The following is a description of a gene set: Mouse Gene Set: GOMF_MRNA_3_UTR_BINDING Binding to a 3' untranslated region of an mRNA molecule. studied in species Mus musculus, and this is the list of marker genes: Utp23, Elavl1 (NCBI Gene Id 97501), Rbm24, Pum1, Khsrp, Larp1, Slirp (SRA stem-loop interacting RNA binding protein), Tia1, Gemin5, Hnrnpa1, Mir135a-1, Elavl3, Exosc7, Dazap1 (DAZ associated protein 1), Syncrip, Cpeb3, Mir9-1, Ddx5, Rc3h1, Mir874, Celf2, Mir24-2, Ago2 (NCBI Gene Id 70188), Mirlet7g, Pum2, Hnrnpd, Taf15, Igf2bp1, Rbm47, Mir24-1, Hnrnpa3, Tardbp, Ybx3, Cpeb4, Secisbp2l, Zfp36l2, Cirbp, Cpsf1, Csdc2, Zfp36l3, Mir21c, Pabpc4l, Dnd1, Trp53, Rbm38, Rbm44, Tut1, Pabpc5, Pabpc1l, Fxr2, Serbp1, Pabpc4, Rnf20, Auh, Mir466l, Ybx2, Hnrnpc, Hnrnpu (NCBI Gene Id 98724), Hnrnpk, Tial1, Igf2bp3, Cryz, Lrpprc, Nova1, Dazl, Cct5, Mir21a, Nudt21, Secisbp2, Exosc4, Exosc9, Nicol1, Exosc8, Celf1, Mir124-2hg, Rbms2, Apobec1, Rnps1, Dhx36, Mir505, Boll, Carhsp1, Arid5a, Rbms3, Hnrnpl, Zfp36, Pabpc6, Hnrnpr, Ilf3, Zar1, Fus, Rbms1, Fxr1, Fmr1, Mir186, Rsl1d1, Zc3h12a, Pcbp1, Hnrnpa2b1, Cpeb2, Zfp36l1, Nhp2, Igf2bp2, Pabpc1, Rpl5, Angel1, Angel2, Zar1l, Larp4b, Mir21b, Zfp385a, Larp4, Qki, Rbm4, Rbfox1, Rbpms, Pabpc2, Pcbp4, Rps7, Btg4, Hnrnpa0, Elavl4, Rnf40, Mex3d, Cpeb1